Given this list of marker genes SLC13A1, SLC25A10, SLC26A6, SLC26A5 (NCBI Gene Id 80269), SLC26A11, UCP2, SLC13A4, SLC26A1, SLC26A3, SLC26A8, SLC26A7, SLC26A9, SLC26A2, SLC26A4, SLC26A10P, RACGAP1, here is a description of the gene set: species: Homo sapiens The directed movement of sulfate across a membrane. Human Gene Set: GOBP_SULFATE_TRANSMEMBRANE_TRANSPORT